The following is a description of a gene set: studied in species Homo sapiens Human Gene Set: GOBP_POSITIVE_REGULATION_OF_CHROMOSOME_CONDENSATION Any process that activates or increases the frequency, rate or extent of chromosome condensation., and this is the list of marker genes: NCAPG2, NCAPD3, SMC2 (structural maintenance of chromosomes 2), NCAPG, NCAPH2, SMC4, NCAPD2 (NCBI Gene Id 9918), NCAPH